Given this list of marker genes Mcub, Slc8b1, Phb1, Phb2 (NCBI Gene Id 12034), Smdt1, Micu1, Yme1l1, Pmpcb, Afg3l2, Micu3, Stoml2, here is a description of the gene set: Reactome Pathway: Mitochondrial calcium ion transport part of: Transport of small molecules electronically inferred by orthology from the curated human pathway This event has been computationally inferred from an event that has been demonstrated in another species.<p>The inference is based on the homology mapping from PANTHER. Briefly, reactions for which all involved PhysicalEntities (in input, output and catalyst) have a mapped orthologue/paralogue (for complexes at least 75% of components must have a mapping) are inferred to the other species. studied in species Mus musculus